Given this list of marker genes SOBP, CCAR2, NEXN (NCBI Gene Id 91624), CD160, IKZF1, POLR2C, GARIN3, RSRC1, HERC5, NR4A2, H4C5, XCL1, NFE2L3, IKZF2, TNFRSF10D, IFNA1, TNK2, here is a description of the gene set: BACKGROUND: The mechanisms underlying smallpox vaccine-induced variations in immune responses are not well understood, but are of considerable interest to a deeper understanding of poxvirus immunity and correlates of protection. METHODS: We assessed transcriptional messenger RNA expression changes in 197 recipients of primary smallpox vaccination representing the extremes of humoral and cellular immune responses. RESULTS: The 20 most significant differentially expressed genes include a tumor necrosis factor-receptor superfamily member, an interferon (IFN) gene, a chemokine gene, zinc finger protein genes, nuclear factors, and histones (P <= 1.06E(-20), q <= 2.64E(-17)). A pathway analysis identified 4 enriched pathways with cytokine production by the T-helper 17 subset of CD4+ T cells being the most significant pathway (P = 3.42E(-05)). Two pathways (antiviral actions of IFNs, P = 8.95E(-05); and IFN-alpha/beta signaling pathway, P = 2.92E(-04)), integral to innate immunity, were enriched when comparing high with low antibody responders (false discovery rate, < 0.05). Genes related to immune function and transcription (TLR8, P =.0002; DAPP1, P =.0003; LAMP3, P = 9.96E(-05); NR4A2, P <=.0002; EGR3, P = 4.52E(-05)), and other genes with a possible impact on immunity (LNPEP, P = 3.72E(-05); CAPRIN1, P =.0001; XRN1, P =.0001), were found to be expressed differentially in high versus low antibody responders. CONCLUSION: We identified novel and known immunity-related genes and pathways that may account for differences in immune response to smallpox vaccination. Genes up-regulated in peripheral blood mononuclear cell stimulated vs unstimulated in adults (18-40) after exposure to Dryvax, time point 9 to 34M. Comment: Original exposure within previous 4 years Human Gene Set: HARALAMBIEVA_PBMC_DRYVAX_AGE_18_40YO_STIMULATED_VS_UNSTIMULATED_9_TO_34MO_UP from publication Haralambieva IH, Oberg AL, Dhiman N, Ovsyannikova IG, Kennedy RB, Grill DE, Jacobson RM, Poland GA (PMID 22949304) species: Homo sapiens